The following is a description of a gene set: Mouse Gene Set: VANDESLUIS_COMMD1_TARGETS_GROUP_4_DN Genes down-regulated in 9.5 days post coitus (dpc) embryos with COMMD1 knockout and in normal 8.5 dpc embryos compared to normal 9.5 dpc embryos. from publication van de Sluis B, Muller P, Duran K, Chen A, Groot AJ, Klomp LW, Liu PP, Wijmenga C (PMID 17371845) COMMD1 (previously known as MURR1) belongs to a novel family of proteins termed the copper metabolism gene MURR1 domain (COMMD) family. The 10 COMMD family members are well conserved between vertebrates, but the functions of most of the COMMD proteins are unknown. We recently established that COMMD1 is associated with the hepatic copper overload disorder copper toxicosis in Bedlington terriers. Recent in vitro studies indicate that COMMD1 has multiple functions, including sodium transport and NF-kappaB signaling. To elucidate the function of Commd1 in vivo, we generated homozygous Commd1 null (Commd1(-/-)) mice. Commd1(-/-) embryos died in utero between 9.5 and 10.5 days postcoitum (dpc), their development was generally retarded, and placenta vascularization was absent. Microarray analysis identified transcriptional upregulation of hypoxia-inducible factor 1 (HIF-1) target genes in 9.5-dpc Commd1(-/-) embryos compared to normal embryos, a feature that was associated with increased Hif-1alpha stability. Consistent with these observations, COMMD1 physically associates with HIF-1alpha and inhibits HIF-1alpha stability and HIF-1 transactivation in vitro. Thus, this study identifies COMMD1 as a novel regulator of HIF-1 activity and shows that Commd1 deficiency in mice leads to embryonic lethality associated with dysregulated placenta vascularization. species: Mus musculus, and this is the list of marker genes: Metrn, C1qtnf3 (NCBI Gene Id 81799), Ckb, Col26a1, Hoxd11, Tppp3, Lhx9, Rspo1, Fabp7, Tmem98, Neurod1, Pax1, Col3a1, Ttpa, Oxct1, Unc5a, Serpinf1